The following is a description of a gene set: Signal transduction in which the initial step occurs in a postsynapse. species: Homo sapiens Human Gene Set: GOBP_POSTSYNAPTIC_SIGNAL_TRANSDUCTION, and this is the list of marker genes: ITPR1, CHRNB2, ARRB2, PLCB1, WNT3A, PRKCB, LARGE1, GNA11, GNAI2, CHRND, PRR7, CHRNB3, GNA15, GNB1, GRK2 (G protein-coupled receptor kinase 2), HRH3, CHRNA4, STAT3, CHRM1 (cholinergic receptor muscarinic 1), CHRM4, RELA, LY6H, CHRNA2, CHRNA6, CHRNB4, CHRNA7, LYNX1, LY6G6D, CDK5R1, CHRNB1, LY6E, GNAQ, CHRNA5, CHRNA1, LY6S, SLURP2, LYPD1, CHRNA3, RNF10, ACHE, CHRM3, RGS10 (NCBI Gene Id 6001), RGS8, PSCA, CRKL, JAK2, CHRM5, OPRM1, HRH4, KPNA1, CHRNG, AGRN, CHRNE, CHRM2